Given this list of marker genes CCKBR, ATP6V1B1, ROGDI, ATP4B, TCIRG1, SLC4A3, ATP4A, here is a description of the gene set: Human Gene Set: GOBP_PH_REDUCTION Any process that reduces the internal pH of an organism, part of an organism or a cell, measured by the concentration of the hydrogen ion. studied in species Homo sapiens